Given this list of marker genes M6pr, Gm4651, Lrtm2, Dcp1b, Cecr2, Slc6a12, 1700030F04Rik, Gm6227, Zfp239, Atp6v1e1, Rimklb, Gm43915, Gm18223, Gm19254, Pex26, 4930540M05Rik, Bms1, Ankrd26 (NCBI Gene Id 70637), Gm10420, Gm22418, Minpp1-ps, Gm24592, Tmem121b, Adipor2, Tuba8, Ninj2, 4933440N22Rik, Mug4-ps, Gm44173, Gm5112, Mical3, Klrg1, Cacna1c, Ret, Mfap5 (NCBI Gene Id 50530), Rpl28-ps4, Dppa3, B4galnt3, Erc1, Mug-ps1, Kdm5a, Fbxl14, Slc25a18, Gm7292, Apobec1, Gm30557, Zfp248, 1700069P05Rik, 6820426E19Rik, Zfp637, Gm4482, Csgalnact2, Bcl2l13, Cxcl12, Ccdc77, Mir7044, Gm10224, Gm30498, Wnk1, Gemin6-ps, Gm9946, Gm6637, 1700063H04Rik, Gm8459, Hdhd5, Gm23908, Zfp9, D030044L04Rik, Phc1, Gm44184, Nanog, Wnt5b, Slc6a13, Rps27a-ps3, A2m, Fxyd4, Mug1, Bid, Cacna2d4, Foxj2, Gm43945, Rad52, Il17ra, Mug2, Gm15532, Rasgef1a, Aicda, Mir706, Gm4875, Gm18981 (NCBI Gene Id 100418069), 1700072O05Rik, Usp18, Gdf3, Gm4640, Slc2a3, Gm7298, Gm44148, Gm10319, Hnrnpf, Iqsec3 (NCBI Gene Id 243621), Gm17812, here is a description of the gene set: Mouse Gene Set: chr6F1 studied in species Mus musculus